The following is a description of a gene set: part of: TCR signaling Reactome Pathway: Phosphorylation of CD3 and TCR zeta chains Prior to T cell receptor (TCR) stimulation, CD4/CD8 associated LCK remains seperated from the TCR and is maintained in an inactive state by the action of CSK. PAG bound CSK phosphorylates the negative regulatory tyrosine of LCK and inactivates the LCK kinase domain (step 1). CSK also inhibits PTPN22 by sequestering it via binding (step 2). Upon TCR stimulation, CSK dissociates from PAG1 (step 3) and PTPN22 (step4) and is unable to inhibit LCK. Furthermore, LCK becomes activated via PTPRC-mediated dephosphorylation of negative regulatory tyrosine residues (step 5). CD4/CD8 binds MHCII receptor in APC and the associated LCK co-localizes with the TCR. LCK is further activated by trans-autophosphorylation on the tyrosine residue on its activation loop (step 6). Active LCK further phosphorylates the tyrosine residues on CD3 chains. The signal-transducing CD3 delta/epsilon/gamma and TCR zeta chains contain a critical signaling motif known as the immunoreceptor tyrosine-based activation motif (ITAM). The two critical tyrosines of each ITAM motif are phosphorylated by LCK (step 7). species: Homo sapiens, and this is the list of marker genes: PAG1, HLA-DPA1, CD3G, HLA-DRB4, TRAC, HLA-DRB3, HLA-DQB2, HLA-DQB1, TRAV8-4, TRAV29DV5, PTPRC, HLA-DQA1, HLA-DQA2, HLA-DPB1, LCK, CD3D, CSK, HLA-DRB1, PTPN22, CD4, HLA-DRA, PTPRJ, TRBC1, CD247, TRAV19, CD3E, TRBV7-9, HLA-DRB5, TRBV12-3